Given this list of marker genes TSPO, GRAMD1B, MTTP, STARD3, GRAMD1C, ABCA1, STAR, ABCG5, APOA2, PLTP, ABCG1, CETP (NCBI Gene Id 1071), GRAMD1A, APOA4, OSBPL2, APOE, NPC1, STARD5, SCP2, APOA5, STARD4, ABCG8, APOB, NPC2, APOA1, here is a description of the gene set: species: Homo sapiens Human Gene Set: GOMF_CHOLESTEROL_TRANSFER_ACTIVITY Removes cholesterol from a membrane or a monolayer lipid particle, transports it through the aqueous phase while protected in a hydrophobic pocket, and brings it to an acceptor membrane or lipid particle.